Given this list of marker genes BLNK, GAB4, CASS4, SH2B1, NRG3, BMPR2, TRIM6, PIK3R2, CBLC, SHC3 (NCBI Gene Id 53358), SQSTM1, NCK1, ACVR1, GAS6, NRG1, PITPNM3, MST1, GRM5, ANGPT4, GHR, ACP4, PHYHIP, DOK2, ELMO2, IRS1, CRK, NCK2 (NCBI Gene Id 8440), GRAPL, DAZAP2, NOX4, ARTN, TRAT1, FRS2, CADM4, DUSP3, YWHAG, SHC4, CLASP2, CEACAM4, EIF3A, EPHA4, MAP3K7, HSP90AA1, PTPN1, ITGAX, PSPN, RACK1, CDH1, PRR7, CBLB, CSK, ARHGEF16, IRS2, CEACAM7, PITPNM2, MST1L, SHC2, FRS3 (NCBI Gene Id 10817), FIZ1, CEACAM1, PTPN14, CD247, DGKQ, ALKAL2, RAB8A, PITPNM1, CRKL, SHC1, TJP2, DUSP22, NEDD9, SOCS5, GFRAL (GDNF family receptor alpha like), SH2B3, GPX1, CDH5, DSCAM, ZPR1, GIT1, GRB14, CEACAM20, MYOC, GAB2, STAP1, FLT3LG, ALKAL1, PIK3R1, KHDRBS1, ERBB2, RNF41, SH2B2, GRB2 (growth factor receptor bound protein 2), TRADD, HYAL2, NRTN, ANGPT1, TOB1, ITGB1 (NCBI Gene Id 3688), SIRPA, TP53, CD4, CEACAM3, CBL, GPRC5B, FNTA, PCNA, PTPN11, ANGPT2, GDNF (NCBI Gene Id 2668), CD2, TREM2, GP6, CPNE3, PTPN2, BANK1, DOCK4, LRP4, PLCG2, here is a description of the gene set: studied in species Homo sapiens Binding to protein tyrosine kinase. Human Gene Set: GOMF_PROTEIN_TYROSINE_KINASE_BINDING